Given this list of marker genes TRH, AVP (NCBI Gene Id 551), AVPR1A, BEST1, RAB3GAP1, NPY5R, APBA1, STXBP1, NF1, PIANP, ADORA2A, SLC38A2, GABBR1, NTSR1, ABCC8, PRKG1, SNCA, NTRK2, GJA1, GIPC1, KCNK1 (NCBI Gene Id 3775), KCNJ8, P2RX7, KMO, SYT4, DTNBP1, GRM2, GRM7, KCNK2, ADORA1, here is a description of the gene set: species: Homo sapiens Human Gene Set: GOBP_GLUTAMATE_SECRETION The controlled release of glutamate by a cell. The glutamate is the most abundant excitatory neurotransmitter in the nervous system.